The following is a description of a gene set: This event has been computationally inferred from an event that has been demonstrated in another species.<p>The inference is based on the homology mapping from PANTHER. Briefly, reactions for which all involved PhysicalEntities (in input, output and catalyst) have a mapped orthologue/paralogue (for complexes at least 75% of components must have a mapping) are inferred to the other species. electronically inferred by orthology from the curated human pathway Reactome Pathway: Proteasome assembly part of: Post-translational protein modification species: Mus musculus, and this is the list of marker genes: Psmd7, Psmc6, Psmd6, Psmc1, Psma7, Psmb6 (NCBI Gene Id 19175), Psmb8, Psmg1, Psma6 (proteasome subunit alpha 6), Psmc4, Psme2, Psmb4, Psmc2, Psma1, Psmb11, Psme1, Psmd12, Psma3, Psmb10, Psme3, Psmg4, Psma5, Psmb9, Psmc3, Psma4, Pomp, Psmd4, Psma2, Psmc5, Psmd13, Psmb7, Psmb5, Psmd1